Given this list of marker genes NCK2, PRKCD, ITGAV, PIK3CA, PAK2, MAP2K3, PIK3R1, FBXW11, PXN, MAP2K2, CDC42, PTK2B, PLCG1, PTPN6, SRC (NCBI Gene Id 6714), GRB2, GAB1, CAV1, PTPN11, VCL, CDH5, HGS, SHB, KDR, IQGAP1, NEDD4, GRB10, CTNNB1, MAP2K6, ROCK1, SH2D2A, AKT1, MAPKAPK2, PRKACA, PRKCA, MAP2K1, MAPK14, PTPRJ, DNM2, PRKCB, FES, NCK1, HSP90AB1, MYOF, VEGFA, BRAF, NOS3, VTN, FYN, MAPK11, PRKAA2, ARF1, RAF1, CTNNA1, PRKAG1, MAPK3 (NCBI Gene Id 5595), AKAP1, RHOA, PTPN2, HSP90AA1, FLT1, CAMKK2, PRKAA1, PDPK1, ITGB3, PRKAB1, CBL, PTK2, MAPK1, here is a description of the gene set: Signaling events mediated by VEGFR1 and VEGFR2 studied in species Homo sapiens Human Gene Set: PID_VEGFR1_2_PATHWAY from publication Schaefer CF, Anthony K, Krupa S, Buchoff J, Day M, Hannay T, Buetow KH (PMID 18832364)